Given this list of marker genes FOSL1, GDF15, CTNNA1, FYN, TUBB, THBS1, SLC9A1, PTPRG, CAVIN1, EPHA2, SPHK1, CLC (NCBI Gene Id 1178), KLF6, IRS2, F3 (coagulation factor III), UPP1, GADD45A, STK17A, DKK1, CAV1, GJB3, ETV5, SLC7A5, SLC3A2, KRT17, SERPINB8, SMURF2, ZYX (zyxin), MAFF, INHBA (NCBI Gene Id 3624), CDC25A, MYO1B, DUSP1, TNFRSF10B, HBEGF, here is a description of the gene set: Human Gene Set: WANG_METHYLATED_IN_BREAST_CANCER studied in species Homo sapiens Treatment of the breast cancer cell line, MDAMB468 with the DNA methylation inhibitor, 5-azacytidine (5-AzaC) results in growth arrest, whereas the growth of the normal breast epithelial line DU99 (telomerase immortalized) is relatively unaffected. Comparing gene expression profiles of these two lines after 5-AzaC treatment, we identified genes that had relatively low basal levels in MDAMB468 cells compared to the DU99 line and were induced in the cancer cell line but not in the normal breast epithelial line. Of these genes, 33 have associated CpG islands greater than 300 bp in length but only three have been previously described as targets for aberrant methylation in human cancer. Northern blotting for five of these genes (alpha-Catenin, DTR, FYN, GADD45a, and Zyxin) verified the array results. Further analysis of one of these genes, GADD45a, showed that 5-AzaC induced expression in five additional breast cancer cell lines with little or no induction in three additional lines derived from normal breast epithelial cells. The CpG island associated with GADD45a was analysed by bisulfite sequencing, sampling over 100 CpG dinucleotides. We found that four CpG's, located approximately 700 bp upstream of the transcriptional start site are methylated in the majority of breast cancer cell lines and primary tumors but not in DNA from normal breast epithelia or matched lymphocytes from cancer patients. Therefore, this simple method of dynamic transcriptional profiling yielded a series of novel methylation-sensitive genes in breast cancer including the BRCA1 and p53 responsive gene, GADD45a. Genes up-regulated in MDA468 cells (breast cancer) vs DU99 cells (normal breast) after treatment with azacytidine. from publication Wang W, Huper G, Guo Y, Murphy SK, Olson JA Jr, Marks JR (PMID 15735726)